The following is a description of a gene set: studied in species Mus musculus Mouse Gene Set: TABULA_MURIS_SENIS_LIMB_MUSCLE_SMOOTH_MUSCLE_CELL_AGEING from publication Tabula Muris Consortium (PMID 32669714), and this is the list of marker genes: Itgb1, Hrct1, Aldh2, Gstt1 (NCBI Gene Id 14871), Ddx5, Isg15, Rgs16, Cfh, Ech1, Ssb, Rbm8a, Rbbp7, Ccl19, Psmb8, B3gnt2, Gucy1b1, Ifit1, Hnrnpk, Ifi203, Cog7, Sbds, Cald1, Plac9, Cpne2, Cdc42, Irgm1, Serping1, Asap2, Lgals3, Nfe2l2, Adamts4, Gnb4, Casp4, Nfkbia, Capg, Gbp7, Mycbp2, Irf1, Rbms1, S100a6, Myo1b, Aldoa, Gbp5, Gucy1a1, Cxcl10, Anxa3, Ifi211, Dnaaf10, Tln1, H2-D1, H2-K1, Iigp1, Ldhb, Rtp4, Anxa5, Tspo, Gpx3, Naf1, Srrm2, Erdr1, Eif2s2, Trex1, Gng11, Pkm, Gpr19, Mnd1, Il6, Tuba4a, Vcam1, Ifi207, Lmod1, Pcdh19, Sncg, Vat1, Inpp4b, Mndal, Yy1, Gstm1, Cyp4b1, Npy1r, Igf2, Ifit3, Filip1l, Ifi47, Rgs5, H2-Q4, Nbeal1, Zeb2, B2m, Acta1, Rsu1